Given this list of marker genes PDE1C, CCDC162P, NUDT15, MYBPC1, PIK3IP1, AMPD3, HERC1, RTN4R, RBPJ, LRRC14B, RPL7AP35, AIMP2, SCARNA2, LPIN1, HDHD5-AS1, EML6, YAP1, TCF7L1, JAKMIP1-DT, FIP1L1, NAA38, RBM24, TANC1, CCNC, LINC01088, SDK1, MYLK3, PTMA, MT-RNR1, KLHDC4, MT-TF, TNK2, MT-TN, RPS7, IFT140, ACSL1, LINC02248, CDK5R1, MT-TA, ARNT2 (NCBI Gene Id 9915), ZNF563, MTA3, SMIM8, PTP4A3, LINC01387, HDHD5, PPP1R12B, PRRC2A, CDS1, IL23R, PDYN-AS1, CELSR1, STIM1, JAKMIP1, LINC01460, E2F6, TMEM70, MT-TP, GAS2L3, COQ8A, MTCH1, ROCK1P1, RPL24 (ribosomal protein L24), MT-TC, TMEM204, TMCC2, EXOSC3, FANCA, PMS2, RUNX1T1, MYRIP, RNA5S12, PYGO1, MT-TY, MIR592, PRUNE2, here is a description of the gene set: Genes containing one or more binding sites for (HEY2) in their promoter regions (TSS -1000,+100 bp) as identified by GTRD version 20.06 ChIP-seq harmonization. Human Gene Set: HEY2_TARGET_GENES from publication Yevshin I, Sharipov R, Kolmykov S, Kondrakhin Y, Kolpakov F (PMID 30445619) species: Homo sapiens